Given this list of marker genes RNF144B, FERMT2, EPHA7, RBM24, NRN1, CPEB3, MAP3K13, OGT, ANKRD46, CCDC88C, ETNK1, SMIM13, LAMC1, SLC4A4, ACVR2B, PCDH9, CPD, PLXNC1, SERBP1, KCNN4, PIP4P2, CCNE1, CCDC83, MAP2K1, CLCN4, RIF1, ADAMTS3, CD3E, RECK, CLOCK, PRDM4, P3H2, ZSCAN31 (zinc finger and SCAN domain containing 31), IGF1R, EGLN1, PRKAR2A, MEOX2, HSPA4L, UBE4B, IGF2R, ABL2, HECTD4 (NCBI Gene Id 283450), LRRK1, USP15, PIK3R1, LRIG2, CMC4, ADGRL1, TBL1XR1, CACNA2D1, DCLK1, ELL2, PTH, SIPA1L2, KIF3B, C1QL3, SAV1, SCN8A, NAPG, FLT3, TLL1, CCND1, NRP2, ATXN7L3, CSDE1, CARM1, CAPRIN1, CYP26B1 (cytochrome P450 family 26 subfamily B member 1), TCAIM, GLS2, RASSF8, SGK1 (serum/glucocorticoid regulated kinase 1), TMEM268, ADAMTS6, NR2C2, ANO3, KIF21A, PCDH17, NHLRC2, RUNDC3B, UBE2Q1, ACVR2A, TMEM154, UNC13A, GHR, LGR5, UNC80, ARFGAP2, UBQLNL, SALL1, MKX, MYO5A, G2E3, CPEB2, UBE4A, HELZ, UBE2V1, SPTBN2, SYDE2, EXT2, LDLRAD2, RNF217, DYRK1B, KIF1B, MOV10, RGMA, MYLK, HECTD1, PEX13, LARGE2, CBX4, ZFHX3, TBPL1, FGF7, ZFHX4, SKI, IKBKB, SSTR3, EDA, JARID2, MAMSTR, SOCS6, IPPK, RSBN1, ARL3, EPB41L4B, GPR63, SEMA5B, DPY19L4, ARPP19, LRRN3, FNTA, SEMA3A, DENND2C, ZBTB39, ATG9A (autophagy related 9A), PTPN3, MYRIP, VEGFA, POU2F1, UBR3, AVL9, TGIF2, CDC42SE2, MEX3C, CNOT6L, MED26, NAV1, ATXN7L3B, RBM12, TENM2, PELI2, ST8SIA3, TMCC1, SETD3, KIF5B, G0S2, UBN2, MGAT4A, TMEM199, CHD2, QKI, SH3GL2, CEP85L, ACTR2, ARHGAP32, PTPRR, IHH, MIDEAS, RAB9B, ANKS1A, LATS1, SEMA3D, NUFIP2, SEMA6D, CUX1, WNT3A, TMEM245, TNRC6B, PABIR2, ZNHIT6, SLC35G1, RBM6, TBP, RASEF, ANXA11, SCOC, BTAF1, EYA1, SVIP, PLAG1, DNAJA2, ZC2HC1A, OOEP, MIB1, MAP3K9, C12orf76, PAFAH1B1, YTHDC1, MOB4, ZNF367, KPNA3, DLEU7, WNT7A, SYT3, CHEK1, MNT, CBX2, DEPDC4, STRADB, TAB3, CD80, PLEKHA1, RS1, KIF23, HIGD1A, ISM2, DDX3Y, LYPLA2, TMEM100 (NCBI Gene Id 55273), LITAF, MYB, WNK3, DCP1A, ARMH4, CYB561A3, WNT4, RPS6KA6, COPS7B, MAP7, N4BP1, SLC6A11, SLC20A2, CASR, CYP2S1, STXBP3, NECTIN1, RBBP6, RREB1, SPTLC1, TRIM66, OTX1, SEL1L3, SLC13A3, SREK1, GABARAPL1, NF1, MBNL2, STXBP5, WWC1, TRANK1, ARMCX2, DENND4A, AHCYL2 (adenosylhomocysteinase like 2), KRTAP4-6, SHOC2, RFK, CHUK, TRAM1, TGFBR3, ZNRF3, EPHB2, SPRYD3 (NCBI Gene Id 84926), LSM11, BMPR1A, RET, STK33, NAA25, ILDR2, WBP11 (NCBI Gene Id 51729), ROCK2, FAM133B, ENAH, SNTB2, TSC22D2, USP42, SALL3, GNAT1, KCNK10, ATG13, BAG4, UROS, CDC25A, DLL1, CDK17, ARL2, LUZP1, MYEF2, GALNT7, EPC1, ZBTB20 (NCBI Gene Id 26137), ISLR, AK4, HEPHL1, AREL1, CLUH, GAREM1, PDK4, RELN, ATXN1L, FGFR1, SRPRA, AXIN2, LURAP1L, PPM1A, RETREG2, CCND2, CD2AP, TMEM178B, EZH1, RASGEF1B, ZDHHC15, TMEM135, SYPL1, MYBL1, MKNK1, OMG, HTR2A, TARBP2, CASK, SAMD10, INSR, BZW1, WIPI2, ELAC1, RNF10, RTN4, SSR1, FAM91A1, IPO7, CACUL1, UNC5D, AGO4, FGF2, TRABD2B, ZC3H13, RIMKLB, CMPK1, SNRPB2, SPAG7 (sperm associated antigen 7), CSRNP1, SLIT2, CDC37L1, FAM81A, PAG1, PEDS1-UBE2V1, ZNF548, PDE3B, SMURF2, ARIH1, RUNX1T1, SLC25A37, CDHR1, MTMR3, ATF6, HMBOX1, ZMAT3, FBXL20, PHF19, PPT2, NSMF, PIAS2, IARS1 (isoleucyl-tRNA synthetase 1), GATAD2A, HTR4, GCC2, PISD, HMGA1, PCMT1 (NCBI Gene Id 5110), PDZD8, SLC36A1, CDC27 (cell division cycle 27), SUZ12, RFX3, SYNRG (synergin gamma), AMMECR1, ASH1L, SLC2A14, YWHAH, ARHGAP12, TMEM183A, SIRT4, KIF5C, UTP25, TFAP2A, SESTD1, TMEM74B, GALNT13, MOB3B, CCNT1, HIPK2, GRM7, KCTD8, BTG2, CXCR5, CLDN12, SYT4, CAPZA2, TUBA4A, ACOX1, NOB1, SLC2A3, MFN2, APLN, USP31, FGF9, HSPG2, SLC39A10, HOXA10, FBXW7, CC2D1B, ST7L, IVNS1ABP, PAPPA, GPATCH8, ATG14, FASN, ATXN2, DRD1, KCNJ2, PTPRD, ZMYM2, DDX3X, PPP6R3, SEC24A, GPN1, AMER1, ZNF449, GFAP, CHPT1, RAB30 (NCBI Gene Id 27314), PTPN4, MAN2A2 (mannosidase alpha class 2A member 2), ATXN7L1, SYNJ1, MTFR1L, FAM89A, RAB11FIP2, COL12A1, NCS1, XPO7, SESN1, SEH1L, KRTAP11-1, CACNA1E, PDIA6, CCNJL, VTI1B, USP44, RAD23B, ARHGAP20, CCDC6, NSG1 (neuronal vesicle trafficking associated 1), ENSG00000275993, BCL11B, YRDC, LRP2, SLC12A2, COP1, LRP6, C1orf21, GSTCD, VPS4A, FBXO21, ZCCHC2, IL7R, CEP55, IFT74, COBLL1, RBPJ, CDK8, SLC11A2, SMURF1, CD47 (NCBI Gene Id 961), ZNF691, BCL2L2, SLC9A6, PLRG1, AMOTL1 (NCBI Gene Id 154810), SUMO3, MYO5B, PIP4P1, PTCH1, FAM110C, ABHD2, ELL, GGA3, ZNRF2, RAB9A, SEPTIN2, LRIG1, HERC6, SOX6, PAFAH1B2, DNAJB4, SIK1, UBFD1, CDK5R1, ZNF622 (zinc finger protein 622), MIGA1, CPSF7, PLXNA4, FAM135A, AGO1, DIXDC1, RPS6KA3, AMOT, KLHL2, WEE1, DMPK, ZCCHC3, PARVA, ZBTB44, SALL4 (NCBI Gene Id 57167), DENND1B, SOBP, CDCA4, C2orf42, BTRC, ABCF3, NFATC3, PPM1E, CHIC1, RAD50, NUP50, ELMOD1, TFCP2L1, PPP2R1B, RSPO3, TLK1, ARHGDIA, RARB, FOXK1, VPS33B, KCNG4, KDSR, E2F3, PNPLA6, SUCO, ZNF704, PLPP1, RORA, SNX16, TTC14, SPRED1, JPH3, CREBRF, STOX2, C2orf72 (NCBI Gene Id 257407), AKT3, NOS1, TMC7, DMTF1, ANKUB1, USP3, MCU, NRBP1, CFAP45, ACSL4, ZBTB34, USP25, CBX6, PPP1R11, ANLN, KANK1, MASP1, SON, SMAD7, ATXN7L2, RICTOR, TNFSF13B, ZBTB46, CHAC1, LAMP3, EXOC3L2, PRRC2C, ADRB2 (adrenoceptor beta 2), DESI1 (desumoylating isopeptidase 1), DYNC1LI2, here is a description of the gene set: studied in species Homo sapiens Human Gene Set: MIR16_5P Genes predicted to be targets of miRBase v22 microRNA hsa-miR-16-5p in miRDB v6.0 with MirTarget v4 prediction scores > 80 (high confidence targets). from publication Chen Y, Wang X (PMID 31504780)